Given this list of marker genes KYNU, PSD2 (pleckstrin and Sec7 domain containing 2), USP12, DHRS7, ST3GAL6, DDX59, ZFP14, RELCH, SLC38A7, TEF, CDC37L1, LANCL1, C2orf42, SPAG9, RCN1, IFI27L2, ZNF784, TLR1, BCOR, MGST2, SLC35B3, AHI1, MPEG1, DOCK6 (dedicator of cytokinesis 6), CEPT1, GALNT4, RGS3, CD72, PRKCQ, LPCAT1, HINT2, TRMT6, GLCE, NSG2, ADAMTS10, AKNA, TAPBP, AKAP7, METTL21A (NCBI Gene Id 151194), ARFRP1, ANKRD49, CRYZL1, SDHAF4, PIGB, PLPP6, S100A11, RRBP1, LGALS4, CFLAR, LPIN1, UNC50, GPR18, VWA7, XAF1, GPX7, OAS2, TEP1, EXTL3, IMP3, SLC2A9, ZNF263, COQ10A, IER5, YPEL3, NAB1, C15orf40, RIMOC1, ALDH4A1, ZNF862, NAE1, SHISA5, CLSTN1, PFKFB4, KDM5B, SFXN5, SLC12A7, KHK, ZNF799, MKNK1, COQ2, ARSB, TMEM31, EXTL2, CHD1L, CD22, AKR7A2, FAM149A, IFNAR1, ECI1, TNFRSF13B, C3orf33, PPM1K, SIRT4, TSPAN2, SFXN2, HLA-DOA, RMND1, BBS4, STARD10, AP4B1, ADI1, TRIM56, GNMT, SRI, TIAL1, ING4 (inhibitor of growth family member 4), CRB3, RREB1, NCF2, ARAF, CRACDL, SKAP1, TOR1B, KLHL17, RMDN1, NUP160, ELL3 (NCBI Gene Id 80237), DYNC1LI2 (NCBI Gene Id 1783), MRGPRE, CLK1, CFAP96, APOBEC2, KLHL22, FAM53A, TMEM100, COL20A1, HMG20A, LDLRAD3, MCOLN1, IAH1, EZH1, ZNF318, ZC3H6, PHC3, MEST, WWOX, RELT, RPS18, USP3, FILIP1L, CEP97, BCL2L2, HERC1, ACSS1, ACAP1, BORCS7, AHDC1, C8orf33, TMCC3, DOK3, PLD4, VPS54, RAB12, FHOD1, SPTLC1, DAO, ALDH1L2, USE1, ABHD6 (abhydrolase domain containing 6, acylglycerol lipase), PTPN18, TRIM39, HLA-E, EARS2, TSHB, STAMBPL1, AGO1, NXPE3, UBTD2, MICAL1, SBK1, CNPY3, GML, ZNF354B, ADCK1 (NCBI Gene Id 57367), NEB, SPART, DALRD3, G6PC3, NDFIP1, PCBP3, DDX5, TMEM209, PTPRE, AZI2, TMED4, ANKRD12, ZYX, RAD52, PLBD1, IFFO2, NUDT16, GPATCH2, PDLIM2, AFP, ZNF217, KCTD21, TPRA1, EEF2K, GPR183, here is a description of the gene set: Genes up-regulated in macrophages with SOCS3: untreated versus IL6 for 400min. Effects of SOCS3 on the transcriptional response of bone marrow-derived macrophages to IL-6. Fetal liver cells from SOCS3+/+ or SOCS3-/- embryos were used to reconstitute recipient mice. Donor derived bone marrow from these mice was differentiated to macrophages. Macrophages were either unstimulated, or stimulated for 100 or 400 minutes with 10 ng/ml IL-6. Human Gene Set: GSE411_UNSTIM_VS_400MIN_IL6_STIM_SOCS3_KO_MACROPHAGE_UP studied in species Homo sapiens from publication Lang R, Pauleau AL, Parganas E, Takahashi Y, Mages J, Ihle JN, Rutschman R, Murray PJ (PMID 12754506)